Given this list of marker genes KDR, ERBB4, TEK, FGFR1, FGFR4, NTRK1, IGF1R, FLT3, PDGFRB, KIT, PDGFRA, NGFR, FGFR3, FLT4, INSR, FLT1, ERBB2 (NCBI Gene Id 2064), NTRK2, MET, CBL (NCBI Gene Id 867, Cbl proto-oncogene), EGFR, ERBB3, FGFR2, EPHA2, CSF1R, here is a description of the gene set: Regulation of GF-RTK-RAS-ERK signaling, ubiquitination of RTK by CBL. Pathway ID: N01599. Pathway type: Reference. Pathway class: nt06526 MAPK signaling. Pathway Definition from KEGG: CBL -| RTK Human Gene Set: KEGG_MEDICUS_REFERENCE_REGULATION_OF_GF_RTK_RAS_ERK_SIGNALING_UBIQUITINATION_OF_RTK_BY_CBL species: Homo sapiens